The following is a description of a gene set: species: Mus musculus Mouse genes annotated to increased thyroid tumor incidence (MP:0010316) retrieved from the Mouse Genome Informatics database via MouseMine Mouse Gene Set: MP_INCREASED_THYROID_TUMOR_INCIDENCE from publication Motenko H, Neuhauser SB, O'Keefe M, Richardson JE (PMID 26092688), and this is the list of marker genes: Edn3, Braf, Rb1, Prkar1a, Pten, Men1